Given this list of marker genes KAT6B, PIGG (phosphatidylinositol glycan anchor biosynthesis class G (EMM blood group)), LETM1, NSD2, CTBP1, NELFA, CPLX1, here is a description of the gene set: Hypoplastic pubic ramus Human Gene Set: HP_HYPOPLASTIC_PUBIC_RAMUS Underdevelopment of a ramus (branch) of the pubic bone. species: Homo sapiens